Given this list of marker genes NDC80 (NDC80 kinetochore complex component), BRME1, CDC25B, TRIM75, MEIOB, UBB (NCBI Gene Id 91253), CCNB2, AURKA, FBXO5, TRIP13, HSF2BP, MEIOC, MLH3, here is a description of the gene set: The cell cycle process in which the first meiotic division occurs in the female germline. species: Homo sapiens Human Gene Set: GOBP_FEMALE_MEIOSIS_I